The following is a description of a gene set: studied in species Homo sapiens part of: Death Receptor Signaling Reactome Pathway: FasL/ CD95L signaling The Fas family of cell surface receptors initiate the apototic pathway through interaction with the external ligand, FasL. The cytoplasmic domain of Fas interacts with a number of molecules in the transduction of the external signal to the cytoplasmic side of the cell membrane. The most notable cytoplasmic domain is the Death Domain (DD) that is involved in recruiting the FAS-associating death domain-containing protein (FADD). This interaction drives downstream events., and this is the list of marker genes: CASP10, FASLG, CASP8, FADD, FAS